Given this list of marker genes KIAA0930, PLSCR4, RASGRP1, CLCN5, PPP2R5E, NXPH1, NFASC, SMC1A, PTGFR, ATP6V1H, RPUSD3, KRT34, SAR1A, DCUN1D5, FAM78B, RHOU, PCYOX1, RAP1GAP2, TAF4B, ZNF550, SH3GL3, ZXDB (NCBI Gene Id 7790), HEPACAM2, KPNA1, RB1, TRIM33, PADI1, TBC1D22B, TSPAN2, SNX27, UQCRQ, PPP1CC, KCNH1, STX3, CDK13, NUP58, MICOS10, SON, SEL1L, WDR5, GCC2, SPATA6, CLTB, SCN3B, CYB5D1 (cytochrome b5 domain containing 1), PRDM1, SPOCK1, GMEB1, CREBZF, PCTP, POFUT2, RAPGEFL1, LHX6, SEC22A, SESN3, HEYL, CERS6, PTPRB, PAFAH1B1, LHX8, ZNF182, OLR1, USP15, CNOT1, RPRD2, TGOLN2, ESF1, BACE2, HARS2, ABHD2, TMEM87B, TULP4, SKP2, ARHGEF12, FUT1, ZFP36L2, CEP19, ACSBG1, PHF13, ZNF333, PAK5, FBXW11, TUBA4A, GBP6, MLLT1, PPARA, MPP3 (NCBI Gene Id 4356), OTX2, MAP3K13, MXD1, TNRC6B, INPP5K, PATE4, NTRK3, VLDLR, ZNF559-ZNF177, GTF2H1 (NCBI Gene Id 2965), PHKA2, KALRN, SLC41A1, SLC22A23, ZFP90, ACE2, ZNF177 (zinc finger protein 177), STK40, PLXND1, ATF2, AAK1, RYK, HIP1, SNX6, SEPTIN11, ABCE1, TLR7, ASH2L, HMOX1, CD28, MEIOB, SLC25A13, TNN, ELOVL7, SNRK, C2orf68 (chromosome 2 open reading frame 68), ILRUN, WIPF2, TTPAL (alpha tocopherol transfer protein like), CELF1, ILDR2 (NCBI Gene Id 387597, immunoglobulin like domain containing receptor 2), MBTD1, TLCD4-RWDD3, HOXA5, ISM1, NAB1 (NGFI-A binding protein 1), SPRED3, ALPL, ANKS4B, EEPD1, HMGCL, VPS54, FAM171A1, DIRAS2, SETD5, SCML4, SLC22A15, MYOZ3, USP5, HOXD10, DRP2 (dystrophin related protein 2), EPHA2, SEC22C, CTNNAL1, ASRGL1 (NCBI Gene Id 80150), EXOC6, GIPC3, ETV5, NME6, RPGRIP1L, here is a description of the gene set: studied in species Homo sapiens Human Gene Set: MIR525_5P from publication Chen Y, Wang X (PMID 31504780) Genes predicted to be targets of miRBase v22 microRNA hsa-miR-525-5p in miRDB v6.0 with MirTarget v4 prediction scores > 80 (high confidence targets).